The following is a description of a gene set: Mutant forms of two enzymes of the pentose phosphate pathway have been associated with disease in humans. A mutation in ribose-5-phosphate isomerase (RPIA), which normally mediates the reversible interconversion of D-ribulose-5-phosphate and ribose-5-phosphate, has been associated with a slowly progressive leukoencephalopathy, and mutations in transaldolase 1 (TALDO1), which normally mediates the reversible interconversion of D-fructose 6-phosphate and D-erythrose-4-phosphate to form sedoheptulose-7-phosphate and D-glyceraldehyde-3-phosphate, have been associated with congenital liver disease. Reactome Pathway: Pentose phosphate pathway disease part of: Diseases of carbohydrate metabolism studied in species Homo sapiens, and this is the list of marker genes: TALDO1, RPIA